The following is a description of a gene set: Fe3+ Ferritin transport. Pathway ID: N01588. Pathway type: Reference. Pathway class: nt06525 Ferroptosis. Pathway Definition from KEGG: ATG5/7 -> NCOA4 -- (Fe3++(FTH1+FTL)) studied in species Homo sapiens Human Gene Set: KEGG_MEDICUS_REFERENCE_FE3_FERRITIN_TRANSPORT, and this is the list of marker genes: ATG7 (NCBI Gene Id 105376952), NCOA4, FTL, ATG5, FTH1